The following is a description of a gene set: A congenital branchial sinus is a remnant of the embryonic branchial arches and their intervening clefts and pouches that has failed to regress completely. Sinuses typically have their external orifice inferior to the ramus of the mandible. They may traverse the parotid gland, and run in close vicinity to the facial nerve in the external auditory canal. studied in species Homo sapiens Human Gene Set: HP_BRANCHIAL_SINUS Branchial sinus, and this is the list of marker genes: SIX1, KDM6A (NCBI Gene Id 7403, lysine demethylase 6A), EYA1, KMT2D, SIX5